Given this list of marker genes Rftn2, Tmtc2, 2510009E07Rik, Rgs8, Plppr4, Pard3, Ino80d, Epb41l5, Fyn, St8sia1, Rab10, Phex, Dusp10, Yipf6, Pdk4, Tcf23, Ivns1abp, Slc22a23, Tmem123, Npy2r, Polr2g, Stard13, Sec31a, Mybpc1, Tsc22d2, Lamp2, Ube2h, Egln3, Fem1b, Ttll9, Ccl11, Evi5, Sntg1, Wdtc1, Kif21a, Tfcp2l1, Zkscan3, Eif4h, Cxcl5, Abtb3, Ptpre (protein tyrosine phosphatase receptor type E), Fgf10, Thsd7a, Celf1, Rbm4, Il23r, Gm525, Pogz, Fam107a (family with sequence similarity 107, member A), Maml1, Iqgap2, Wdr37, Tada1, Cldn2, Snhg11, Rab35, Rprd2, Trim66, Usp17la, Slc25a25, Vgll3, B3galt1, Enpp4, S2bpcox16, Nup155, Gm10408, Ss18l1, Schip1, Cnot4, Nfatc3, Etv6, Pik3cb, Cdh20, Bach2, Lin28a, Ttc39b, Ccdc80, Gm14743, Cacna1a, Tmem33, Cldnd1, Cemip, Tmed8, Sntg2, Tbl1xr1, Txlna, Eml4, Cntn3, Pkd2, Repin1, Scai, Rbbp4, Zeb2, Glra2, Zbtb14, E2f3, Rrp1b, Nox1, Zfp644, Mkx, Tnfaip8l3, Rad9a, AI593442, Serpinb5, Pknox1, Nfat5, Atrn, Gatd1, Pcdh18, Xpr1, S1pr2, A2ml1 (NCBI Gene Id 407806), Obp1b, Ercc6, Fst, Prrg1, Fbp1, Zfp35, Nsd1, Garin2, H2-Eb2, Ano7 (anoctamin 7), Top1, Sfxn3, Fam83f, Phf24, Pdzrn4, Smad2, Snx15, Magi1 (NCBI Gene Id 78178), Stk4, Celf4, Plekhd1, Leng8, Lmnb1, Fat4, D630045J12Rik, Nrxn1, Pcdha8, Pak3, Nf1, Rnf11, Nhsl2, Ptbp3 (NCBI Gene Id 99962), Stxbp5, Sema3a, Ubn2, Zc4h2, Sec14l1, Taf15, Dync1li2, Ctdspl, Pik3ip1, Baz2a, Zcchc4, Hbs1l, Adam22, Arhgap19, Cd38, Nhlh2, Vmn1r171 (NCBI Gene Id 81012), Nebl, Pcdhb13, Rundc3b, Pogk, Prpf39, Lmna, E2f7, Sgip1, Sestd1, Mga (MAX gene associated), Cd300lg, Aida, Trmt10a, Kcnj2, Strn3, Atp11b, Mlec, Abhd5, Cyp7a1, Ubqlnl, Atg4c, Gatm, Gucy1a2, Cask, Aak1, Ano5, Socs4, Cpq, Elavl2, Myadm, Siglecl2, Clcn5, Hs2st1, Tbc1d15, Ctnnd1, Asxl2, Glul, Rab5b, Peg10, Aff1, Neto1, Asb13, Otud7b, Srsf9 (serine and arginine-rich splicing factor 9), Lgi2, Tlcd4, Sp1, Rev3l, Odf2, Prickle2, Prelid3a, Arhgap36, Hesx1, Grm5, Eif4ebp2, Sell, Gm14744, Bard1, Homer2, Loxhd1, Ncald, Bmp7, Usp29, Ankrd44, AW554918, Aqp7, Mbnl1, Tmem52b, Rp2, Stxbp6, Zfp36l2, Dgkk, Naa50, Celf2, Ttc14, Prdm1, Gm21992, Fzd5, Fktn, Htr4, Smarcc2, Sec22c, Osbpl6, Rps6ka6, Tpgs2, Zfp655, Kdm5d, Usp22, Tmc1, Map3k9, Iqschfp (NCBI Gene Id 100505386), Erv3, Gabra1, Clvs2, Psen2, Pclaf, AI837181, Tnrc6b, Tmem181a, Tpm2, LTO1, Itga4, Sec63, Pdgfrl, Bptf, Lrrc8c, 5430402E10Rik, Six2, Peds1, Fxyd6, Nsd3, Hand1, D830030K20Rik, Strbp, Chd3, Jmy (junction-mediating and regulatory protein), Pln, Cntd1, Atp2b4, Rfx3, Tpm4, Atg5, Bmpr2, Snx19, Cap1, Slc7a11, Epm2aip1, Ahcyl1, Oxsm, Dusp11, Usf1, Ro60, Gmcl1, Cox16, Trp53inp2, Ids, F8a, Cyp2c38, Trappc13, Megf9, Slc18a1, Senp7, Fbxl14, Smu1, Eapp, Mapkap1, Celf6, Usp10, Rdh1, Ppargc1a, Dcaf7, Ptgfrn, here is a description of the gene set: Mouse Gene Set: MIR_1958 Genes predicted to be targets of miRBase v22 microRNA mmu_miR_1958 in miRDB v6.0 with MirTarget v4 prediction scores > 80 (high confidence targets). from publication Chen Y, Wang X (PMID 31504780) studied in species Mus musculus